Given this list of marker genes TMEM121B (NCBI Gene Id 27439), XXYLT1, SMARCD1, USP32, GNB4, TENT5A, GRM5, RUNX1T1, SUMO1, EYA4, GMCL1, ARHGAP12, PCDH17, THNSL1, HMGCLL1, CAP1 (cyclase associated actin cytoskeleton regulatory protein 1), FTL, MAML1, ZBTB10, HS2ST1, PPP2CA, CMTM6, XPO1, XPO4, JAZF1, PAX7, PRRT2, FBXW11, SNRK, EMP2, MKRN3, C18orf54, CNN2, PSMD5, CTXN2, RSRP1, CYRIA, AFAP1, RBPJ, CLTA, ZSCAN16 (zinc finger and SCAN domain containing 16), MAEA, SMARCA2, CETN3, BNIP3L, SP1, PITPNM2, ARL13B, PRPS2, RAP2C, PAN3, SP3, IQGAP2, EGFR, EDEM1, SQLE, FUCA1, EXD2, SYT2, BTBD10, CUL4B, IFIT1, UBA2, ZNF710 (NCBI Gene Id 374655), SIMC1, YPEL2 (yippee like 2), NUP153, LHX5, FAM117B, MSN, BTBD3, TXLNA, ANKRD28, AFTPH, ARRB1, ZNF131, ACAT2, GDNF, TRIM55, ZIC3, CTBP2, FBXL2, SH3GL2, OSBPL11, ARL14, FAIM, PRDM1 (NCBI Gene Id 639), TAGLN2, ARPP21, PRAF2, KCTD20, CNOT1, TGFBR1 (NCBI Gene Id 7046), RAPH1, RIMS1, LDLRAP1, CMPK1 (NCBI Gene Id 51727), PDIK1L, CELF5, FOXL2, FHIP2A, PLEKHA3, GRID2, SF3B4, GPM6A, LHFPL6, SGK1 (serum/glucocorticoid regulated kinase 1), SAMD5, DMXL1, BICC1, PRELID3B, IDH1, SGMS2, TWIST2, PTPRK, PPP2R2D, RAB5C, TET3, ELAVL1, FAM117A, DMXL2, SLC30A7, PFN2, RBMXL1, POLR2J, KIF21A, MMP15, RIC1, MYRF, SLC50A1, POU2F2, COL25A1, KCNA6, TMEM167A, ZC3H11A, SV2A, GARNL3, SEC61B, NCAN, PTPRZ1, FBN1, MLLT3, STXBP6, DYNLT3, PTBP1, PTBP2, KIF3C, ELFN1, PEAK1, TMEM170B, ZC3H14, THRAP3 (NCBI Gene Id 9967), PML, ANKRD12, SLC25A38, ADCYAP1, CAPN15, TENM1, CCNC, RAVER1, TLCD3A, ARFGEF1, ARPC5, CKAP4, VIRMA, EPHA7, SGTB, NUP160, MTMR4, PTPRD, ADAMTS5, SLC39A1, VPS54, TFG, TOR1AIP2, FOXP4 (NCBI Gene Id 116113), OSCAR, GDI2, CSNK1G3, MPIG6B, EPHA5, CPNE3, TTPAL, TRIQK, TTYH3, YAF2, SOBP, GABARAPL1, LANCL2, RARB, RFFL, PLCL2, MACO1, WASF2, UBE2Q1, TFAP2D, ASH1L, PTPRO, RBMX, DYNC1LI2, EIF4A1, C11orf58, TIMM17A, PTH1R, SHISA5, ZNF362, DOLPP1, ENC1, MYH9, RB1CC1, B3GNT2, PEX5L, CREB5, GABPB2, RBMXL2, TBPL1, NELL2, TRAM2, TMEM128, YES1, SGPP1, SYT1, ATP7B, GRIA2, TAOK1, SACM1L, PPP2CB, PAPLN, FADS1, GRM7, DHX32, ZNF280C, EBF2, CELF4, PTBP3, FGF1, DUSP1, LASP1, ADAMTS19, VKORC1, ANKRD44, HIC2, SLC6A1, here is a description of the gene set: studied in species Homo sapiens Human Gene Set: MIR133A_3P_MIR133B Genes predicted to be targets of miRBase v22 microRNA hsa-miR-133a-3p, hsa-miR-133b in miRDB v6.0 with MirTarget v4 prediction scores > 80 (high confidence targets). from publication Chen Y, Wang X (PMID 31504780)